Given this list of marker genes CRYBA1, PTRH2, TLE5, MYBBP1A, BRMS1, CHEK2, SIK1, here is a description of the gene set: studied in species Homo sapiens Any process that activates or increases the frequency, rate or extent of anoikis. Human Gene Set: GOBP_POSITIVE_REGULATION_OF_ANOIKIS